Given this list of marker genes BAZ1A, CXCL8, SLC39A14, PMAIP1, INHBA, CEBPD, FLRT3, NFKB2, INTS6, BMP5, HOXA5, BTG3, LGR5, SLC31A2, PLAUR, TGIF2, JUNB, CDKN1A, SERPINE1 (serpin family E member 1), VDR, TAPBP, HERPUD1, RXRA, FOXO1, TTC27, PLAU, BIRC2, RGS2, IL27RA, IRGQ, CXCL2, IER3, LDLR, PLAC8, KLF6 (KLF transcription factor 6), ID1, RNF44, LIF, NAP1L1, CYLD, EFNB2, BMP2, PDE8B, PPIF, PTHLH, NEDD4L, CXCL3, BDNF, HIVEP2, IL4R, NFKBIE, ID3, PITX2, IL6ST, HIVEP1, TRIB2, NKX3-1, REL, FJX1, ADM, DLEU1, BID, TNC, CITED2, KANK2, ITGAV, DUSP10, LAMC1, AURKA, IFNGR2, CREB1 (NCBI Gene Id 1385), DUSP1, HOXA9, PLK2, TNFRSF10B, GABARAPL1, GPRC5A, JUN, MAFF, IL6, TNFRSF21 (TNF receptor superfamily member 21), SLC12A7, ZNF395, COL7A1, PTGER4 (prostaglandin E receptor 4), KLHL21, DNAJB4, KDM6B, SERPINB2, ARL14, PTX3, HEXIM1, CALHM2, CXCL1, SLC20A1, TRAPPC4, SLC5A3, LBH, FNDC3B, DNAJB9, PGRMC2, KYNU (kynureninase), ID2, LHFPL6, TNFAIP3, MFHAS1, TGFA, TGFB2, TPST1, CCNG2, CCL20, ITPRID2, TOB1, BAHD1, FGD6, LITAF, CHST11, INSIG1, FOSL2, TSC22D2, AGRN, KCNN4, EGFR, BCL6, KLRC1, SQSTM1, C3orf52 (NCBI Gene Id 79669), WWC1, THBS1, ALCAM, MCL1, SDF2L1, NAMPT, TANK, SMAD3, NBN, SNCA, HEY1, IRS1 (NCBI Gene Id 3667), CDH19, TIPARP, GABRA2, TCF7L2, STAT3, GLIPR1, B4GALT1, PLPP3, TUBB2B, TUBB2A (tubulin beta 2A class IIa), TNS3, DKK1, PCDH7, CD44 (NCBI Gene Id 960), RIPK4, HAS2, NR2F2, TCIM, SEMA3C, NUAK2, TENT5A, EREG, SPHK1, FZD7, here is a description of the gene set: Genes whose expression changes in Calu-6 cells (lung cancer) by TNF were blocked partially by p38 inhibitor LY479754. Human Gene Set: PHONG_TNF_RESPONSE_VIA_P38_PARTIAL from publication Phong MS, Van Horn RD, Li S, Tucker-Kellogg G, Surana U, Ye XS (PMID 20516219) p38 mitogen-activated protein kinase (MAPK) is rapidly activated by stresses and is believed to play an important role in the stress response. While Chk1 is known to mediate G(2) DNA damage checkpoint control, p38 was also reported to have an essential function in this checkpoint control. Here, we have investigated further the roles of p38 and Chk1 in the G(2) DNA damage checkpoint in cancer cells. We find that although p38 activation is strongly induced by DNA damage, its activity is not required for the G(2) DNA damage checkpoint. In contrast, Chk1 kinase is responsible for the execution of G(2) DNA damage checkpoint control in p53-deficient cells. The inhibition of p38 activity has no effect on Chk1 activation and gamma-H2AX expression. Global gene expression profiling of cancer cells in response to tumor necrosis factor alpha (TNF-alpha) revealed that p38 plays a strong prosurvival role through the coordinated downregulation of proapoptotic genes and upregulation of prosurvival genes. We show that the inhibition of p38 activity during G(2) DNA damage checkpoint arrest triggers apoptosis in a p53-independent manner with a concurrent decrease in the level of Bcl2 family proteins. Our results suggest that although p38 MAPK is not required for the G(2) DNA damage checkpoint function, it plays an important prosurvival role during the G(2) DNA damage checkpoint response through the upregulation of the Bcl2 family proteins. species: Homo sapiens